The following is a description of a gene set: GRIA2+ arterial endo from publication He P, Lim K, Sun D, Pett JP, Jeng Q, Polanski K, Dong Z, Bolt L, Richardson L, Mamanova L, Dabrowska M, Wilbrey-Clark A, Madissoon E, Tuong ZK, Dann E, Suo C, Goh I, Yoshida M, Nikolić MZ, Janes SM, He X, Barker RA, Teichmann SA, Marioni JC, Meyer KB, Rawlins EL (PMID 36493756) species: Homo sapiens Human Gene Set: HE_LIM_SUN_FETAL_LUNG_C3_GRIA2_POS_ARTERIAL_ENDO_CELL, and this is the list of marker genes: GCH1 (NCBI Gene Id 93984), HEY1, PLLP, ATP13A3, SMAD7, BMF, PDK3, SH2D4A, SNX18, HIP1R, CXCR4, SMAD6, CDK19, TRAK1, NTRK2 (neurotrophic receptor tyrosine kinase 2), SLC45A4, TGFB2, MERTK, ASS1, PIK3R3, COL15A1, AFAP1L2, CKB, ABCC4, FBLN5, UNC5B, RAVER2, LYPD2, PRND, LTBP1, SIPA1L2, SOX13, ASRGL1, C1orf115, SSTR1, SEMA3G, CXCL12, SRGN, GPER1, GATA6, KL, MECOM, EGFL8, DUSP4 (NCBI Gene Id 1846), RELL1, PIK3C2B, MIR503HG, RNF144B, ITGB4, SULT1E1, GIPC2, C7, SYNJ2, PDLIM1, RAPGEF1, MYO1E, TMC7, DHH, CYTH3, JAG2, AIF1L, ENPP2, ST8SIA6, PREX2 (NCBI Gene Id 80243), APOL4, SORBS2, GJA5, PLCG2, ADAMTS6, SULT1B1, CFH, PALLD, AMD1, GRIA2, TMEM100, APOA1, SLC35F3, PDGFB, HES4, SOX6, CHRM3, ADAMTSL1, FUT8, VEGFC, COBLL1, FILIP1L, SSUH2, MPPED2, TSPAN2 (tetraspanin 2), SLC6A6, EPS8, IGFBP3, DKK2, CYP26B1, LPCAT2, LTBP4, GCNT1, FAT4, SERPINE2, TFPI2, ADCY1, LAMA5, THSD7A, TNFRSF1B (NCBI Gene Id 7133), MCC, SYNPO, TM6SF1, NR4A1, PCSK5, MET, GFOD1, JAG1, TNFRSF19, IL11RA, SH3BP4